Given this list of marker genes GADD45GIP1, FASTKD3, EXO5, FAM182A, PCDHB3, AOC3, IMPDH2, GALNS, LARP4B, CATSPERB (NCBI Gene Id 79820), NIPSNAP2, NKIRAS2, HOXA1, TTC13, INTS11, COLGALT1, ANKS1A, ZC4H2, PALM, TDP1, SF3A3, CUEDC1, RIN2, SERTAD2, CTSH, TSPYL4, GLRX2, RBMS2, TBP, THOC6, PSTPIP2, MOB1A, POU4F3, MYRIP, ATP6V0E2, SLC18A1, FLVCR2, GFRA3, WDR44, FBXW4, PAFAH1B1, RPS15A, PDGFD, RDH14, ETFB, THYN1, ARFIP1, NUMA1, ALDH2, NIP7, VPS16, SMO, CA10 (NCBI Gene Id 769), PSD3, EBAG9, TRAF2, RARS2, STAT2, DPP3, DRG2, VENTX, OPRD1, PAQR4, DDX27, SPATA2, TUBGCP4 (tubulin gamma complex component 4), NDUFS3, NELFCD, MC3R, TM7SF3, SREBF1, HSDL2, DIABLO, IL6, RBM14, EXTL3, SLC12A9, ARL5A, LPXN, ZNF263, GRWD1, RALGPS1, SPINK4, SH3BGRL, FAM53C, FRG1JP (NCBI Gene Id 642236), SNHG32, KLF1, CASP4, PTCD3, RNASE6, DOP1A, EIF3I, TNFAIP8, GRAMD4, RPL39, KCNF1, IDH1, CHUK, LSM14B, B3GNT2, CCT7, PCNA, PRKRA, MAPK12, CRELD2, PSEN1 (NCBI Gene Id 5663), MAPK14, SCRIB, ODF2, WARS1, PIGH, FCGBP, CNTRL, RALGPS2 (Ral GEF with PH domain and SH3 binding motif 2), TSPAN14, MUC6, NDUFA7, INSL5, MUS81, CSF3, NCAPD3, WDR91, SCN1A, ECHDC1, POLE3, CIB1, SIK1, BCCIP, CSF2 (colony stimulating factor 2), DUSP22, KAT6A, FBXO31, TNP1, ELL, TSSK2, GABPB1, SRSF9, HAUS2, PTS, GPATCH3, BRD3, MAN1B1, ATP6V1G2, MYLK, FBXL12, GPI, HADHA, SH3BP2, CPSF4, RASA1, TUBB, AOC2, SFXN3, ABHD18, HDAC3, CEP170, IFT52, RAPGEFL1, DOK2, ZNF562, GYS2 (NCBI Gene Id 2998), CHRNA2, MAP3K1, KATNB1, PYY, TMEM39B, BNC2, UCHL5, LINC00837, SOD1, USP6NL, SLC25A1, GPR157, TBL3, CD40LG, THOC7, POMC, MAPK8IP1, NME3, IPCEF1, GRID2, LHFPL6, SIRT1, DERA, AGL, UGGT1, CRTC3, TOMM20, ATXN1, ATP5F1A, TM9SF4, TMED2, IKBKG, LRP5, here is a description of the gene set: Human Gene Set: GSE25846_IL10_POS_VS_NEG_CD8_TCELL_DAY7_POST_CORONAVIRUS_BRAIN_DN species: Homo sapiens Genes down-regulated in CD8 T cells: IL10+ versus IL10-. IL-10 is an anti-inflammatory cytokine that has been shown to be produced by antigen-specific CD8 T cells at the peak of viral encephalitis. We found that IL-10+CD8 T cells are more activated and cytolytic than IL-10-CD8 T cells. We used microarrays to detect gene expression changes in directly ex vivo sorted CNS IL-10+ and IL-10- CD8 T cells from a neurotropic J2.2-V-1-infected mouse. from publication Trandem K, Zhao J, Fleming E, Perlman S (PMID 21317392)